The following is a description of a gene set: Neighborhood of PPP1CC Human Gene Set: MORF_PPP1CC species: Homo sapiens Neighborhood of PPP1CC protein phosphatase 1, catalytic subunit, gamma isoform in the MORF expression compendium, and this is the list of marker genes: IMPDH2, LRPPRC, PABPC4, H2AZ1, HDAC1, DUT, XPO1, SREBF2, CHAF1A, RFC4, ELOVL5, CBFB, TGDS, GTF2A2, VDAC1, PRPF8, SNRNP200, PDIA6, ANAPC5, ATP5PO, POM121, PIBF1, SSRP1, PPP1CC, NONO, XRCC5, ATXN10, SLBP, TUBA3E, VDAC3, SRRM1, KHSRP, IMMT, SLC35E2A, NSD2, KIFC1, SF3A3, TYMS, MRPS27, TOMM70 (translocase of outer mitochondrial membrane 70), GOT2, PPT1, STK24, NAE1, HCFC1, PRPS2, UBE2S, TARS1, NUDC, EIF3I, SMC3, DEAF1, AKR7A2, SRSF9, DKC1, TNPO3, NDUFV1, GNB1, SRSF1, CS, RUVBL2, KXD1, LMNB2, CDC16, DGUOK, PTDSS1, ATP5MC3, ESPL1, USP1, PMEL, RPIA, ABCB7, SMARCC1, XPO7, PPM1G, SAFB, BUB3, SSBP1, CLPP, NASP, IFRD1, PPIE, IARS1, TCP1, NNT, KHDRBS1, PAICS, LBR, PRKDC, RO60, SDHB, PTTG1, NUDT1, TREX2, GPN1, BAZ1B, MDC1, EDC4, MTREX, R3HDM1, LSM2, HNRNPU, MAPRE1, UQCRC1, TUBA3C, GNG5, MCM6, DDX19B, STMN1, HDAC2, UPF3A, SEC63, SHMT2, DNAJC9, HNRNPR, AFG3L2, BUB1, CBR4, FH, UBE2D2, DDX21, TUFM, ZWINT, SRPK1, CCT8, RBBP4, TRA2B, CCT5, ANP32A, SRP72, MCM2, IPO5, DCTD, HADH, RNF44, G3BP2, SNRPA, EIF1AX (NCBI Gene Id 83754), IPO7, TFDP1, MLEC, DNMT1, RAD23A, ZNF131, RMND5A, MCM3, HDDC2, EIF4EBP2, ASXL1, EPRS1, ESD, XPOT, VDAC2, AK2, AASDHPPT, NDUFC1, NPM3, SERBP1, PTGES3, GARS1, YARS1, MYCBP2, ERP29, TCEA1, HNRNPD, RRM1